The following is a description of a gene set: Binding to a neurotrophin receptor. studied in species Mus musculus Mouse Gene Set: GOMF_NEUROTROPHIN_RECEPTOR_BINDING, and this is the list of marker genes: Bex3, Plcg1, Ntf3, Bdnf, Ntf5, Nradd, Zfp110, Ntrk1, Pik3r1 (NCBI Gene Id 328326), Ngf, Frs2 (NCBI Gene Id 327826), Grb2, Efna5, Zfp369, Shc1, Ngfr